The following is a description of a gene set: electronically inferred by orthology from the curated human pathway studied in species Mus musculus This event has been computationally inferred from an event that has been demonstrated in another species.<p>The inference is based on the homology mapping from PANTHER. Briefly, reactions for which all involved PhysicalEntities (in input, output and catalyst) have a mapped orthologue/paralogue (for complexes at least 75% of components must have a mapping) are inferred to the other species. part of: Non-canonical inflammasome activation Reactome Pathway: CASP5-mediated substrate cleavage, and this is the list of marker genes: Gsdmd, Casp4, Casp3